Given this list of marker genes CYP21A1P, UXT, KCNC1, RGL2, PRAP1, PSD3, TRAPPC2B, LYNX1, MOCS3, DYRK1B, FKBP2, MSMO1, ACSL3, RDH11 (retinol dehydrogenase 11), NDNF, C1GALT1, MGA, CEP43, SLC41A1, PRSS16, MCTS1 (NCBI Gene Id 28985), UGP2, INTS4, ANKRD13D, YJU2B, BRS3, ZNF266, FBXO21, CD48, RAPGEF4, TYW3, REXO2, TTC33, RAPGEF3, HNF1A, SLAMF7, SSMEM1, TAF10, ARMCX2, RPF2, VEZF1, NEDD8, GLOD4, MTMR14, GINM1, HNRNPA2B1, MTHFS, WTAP, DESI2, RER1, SELENOV, KTN1, SEC23A, GEMIN6, UCHL3, SARNP, DUS2, RSAD1, RPS6KB1, CSTF2T, AP3S2, UBE2H, FAM204A, LATS1, OST4 (NCBI Gene Id 100128731), SERPINB7, SLC25A24, TCF4, COMMD8, RBX1, MFGE8, ALG5, CYSRT1, PCSK1N, EPCAM, ERP27, MRPS23, NXPH3, MYL2, CMPK2, COMMD10, PRADC1, GRHL2, SERP1, LY86, CD9, DUSP11, CCDC136, LETM2, MFF, KRT72, ARHGAP17, AKAP7, VDAC3, RMND1, TMEM92, H2AC25, SLC25A15 (solute carrier family 25 member 15), CUTC, NSMCE1, TSPAN13, BARX2, TCEANC2, CLDN12, ZFP36L1, ENDOU, MID1IP1, CPOX, MED30, GTF2E1, HEXB, ZNF493, ARL6IP6, HENMT1, ARL5A, CAMK4, KCTD14, FH, HYLS1, DYNLT3, PIK3C3, FANCC (FA complementation group C), TENT5A, NDFIP1, PDCD10, FCRLA, CHML, UBA2 (ubiquitin like modifier activating enzyme 2), ADAM33, HLF, FGF4, POLR2K, MORF4L1, ZNF708, RBFOX2, HIF3A, WNT10B, VCPIP1, RAB17, NDUFS5, FSIP1, CSRP2, OOSP2, MPC1, EGFL7, TSPOAP1, AJM1, MYL11, PLA2G2C, ZNF212, GNE, CUL7, CDCA4, FAM8A1, TOMM70, NMBR (neuromedin B receptor), KHDRBS1, TLE1, SDC1, NDUFA1, ANKLE2, LMO4, RTN4IP1, GPR155, JCHAIN, AFP, ABT1, SLC35E3, H2BC3, OPN1LW, TIGD3, OPN3, ZNF235, BET1, STAT2, UNC119B, VPREB3, FAS, SEC16B, LARS2, JMJD4, GRIP2, TACSTD2, CD93, BCL6, NOL7, TAF15, SUOX, ALG14, YPEL3, ANXA4, TMCO1, CRIPT, CBX1, AQP2 (NCBI Gene Id 359), LYPLA1, FAM163B, CTSH, GK2, TMEM108, here is a description of the gene set: species: Homo sapiens from publication Doering TA, Crawford A, Angelosanto JM, Paley MA, Ziegler CG, Wherry EJ (PMID 23159438) Human Gene Set: GSE41867_NAIVE_VS_DAY8_LCMV_ARMSTRONG_EFFECTOR_CD8_TCELL_UP Genes up-regulated in CD8 T cells: naïve versus effectors at day 8 after acute infection with LCMV-Armstrong. During acute viral infections, naïve CD8+ T cells differentiate into effector CD8+ T cells and, after viral control, into memory CD8+ T cells. Memory CD8+ T cells are highly functional, proliferate rapidly upon reinfection and persist long-term without antigen. In contrast, during chronic infections, CD8+ T cells become “exhausted” and have poor effector function, express multiple inhibitory receptors, possess low proliferative capacity, and cannot persist without antigen. To compare the development of functional memory T cells with poorly functional exhausted T cells, we generated longitudinal transcriptional profiles for each.